Given this list of marker genes ERAP2, PSMB8, PSME1, PSMC5, TAP1, NGLY1, HMGCS1, SERP1, PSME4, PSMC1, PSMA3, PSMA6 (NCBI Gene Id 87553), TMED4, PSMB2, PSMD7, PDIA6, PDIA3, PDIA5, PSMA7, PSMC3, PSMA1, GGA3, HLA-B, TAP2, ATF4, PSMD14, HLA-C, SEC22C, PSME3, PSMC2, PSMD5 (proteasome 26S subunit, non-ATPase 5), KDELR1, PSME2, TAPBPL, PSMB10, PSMD8, PSMA2, CANX, ERAP1, PSMB5, HLA-A, PSMF1, TAPBP, PSMB9, PSMB6, PSMC6, PSMD11, PSMA4, DERL1 (NCBI Gene Id 79139), here is a description of the gene set: species: Homo sapiens from publication Pellicciotta I, Cortez-Gonzalez X, Sasik R, Reiter Y, Hardiman G, Langlade-Demoyen P, Zanetti M (PMID 18829567) Histone deacetylases (HDAC) modify the architecture of chromatin, leading to decreased gene expression, an effect that is reversed by HDAC inhibition. The balance between deacetylation and acetylation is central to many biological events including the regulation of cell proliferation and cancer but also the differentiation of immune T cells. The effects of HDAC inhibition on the interaction between antitumor effector T cells and tumor cells are not known. Here, we studied presentation of a universal self-tumor antigen, telomerase reverse transcriptase, in human tumor cells during HDAC inhibition. We found that HDAC inhibition with trichostatin A was associated with a decreased presentation and diminished killing of tumor cells by CTLs. Using gene array analysis, we found that HDAC inhibition resulted in a decrease of genes coding for proteasome catalytic proteins and for tapasin, an endoplasmic reticulum resident protein involved in the MHC class I pathway of endogenous antigen presentation. Our findings indicate that epigenetic changes in tumor cells decrease self-tumor antigen presentation and contribute to reduced recognition and killing of tumor cells by cytotoxic T lymphocytes. This mechanism could contribute to tumor escape from immune surveillance. Antigen processing and presentation genes down-regulated in JY cells (B lymphocytes) treated with trichostatin A (TSA). Human Gene Set: PELLICCIOTTA_HDAC_IN_ANTIGEN_PRESENTATION_DN